Given this list of marker genes Creg1, Tmem199, Cln5, Cln3, Lamp1, Snapin, Tmem9, Cln6, Ppt1, Ccdc115, Atp6v0c, Atp6ap2, Lamp2, Grn, Tmem106b, here is a description of the gene set: Mouse Gene Set: GOBP_LYSOSOMAL_LUMEN_ACIDIFICATION Any process that reduces the pH of the lysosomal lumen, measured by the concentration of the hydrogen ion. species: Mus musculus